The following is a description of a gene set: species: Homo sapiens Human Gene Set: GOBP_CELLULAR_RESPONSE_TO_UNFOLDED_PROTEIN Any process that results in a change in state or activity of a cell (in terms of movement, secretion, enzyme production, gene expression, etc.) as a result of an unfolded protein stimulus., and this is the list of marker genes: QRICH1, DDIT3, SERP1, COPS5, NCK1, EIF2S1, STUB1, CCND1, TM7SF3, ATF6, TMBIM6, DERL1, MIR199A1, CREBRF, MBTPS1, OS9, OPTN (NCBI Gene Id 337928), AKT3, HERPUD1, BCL2L11, AMFR, RHBDD1, DNAJB9, VAPB, UMOD, YOD1, BHLHA15, MBTPS2, HSPB8, DNAJC10, CREBZF, BAX, ATAD3A, MANF, TMTC4, PACRG, PIGBOS1, AKT2, BBC3, RACK1, ATF4 (activating transcription factor 4), TMBIM4, PTPN2, PRKN, TBL2, HSF1, AKT1, SELENOS, DAB2IP, TMEM33, CTH, CDK5RAP3, NCK2, EDEM3, NFE2L2, ERMP1, DAXX, PIK3R1, EDEM2, STC2, PARP6, PARP16, DERL2, HSPA1A, SERP2, ERLEC1, EIF2AK3, DDRGK1, BAK1, CREB3, HSPD1, ASB11, ERO1A, PARP8, RPAP2, ERN2, WFS1, BAG3, CREB3L1, ABCA7, ERN1, PTPN1, VCP, BOK, RHBDD2, XBP1, DERL3, TMED2, RNF7, PPP1R15B, ATF6B, ATF3, FUT1, UFL1, ABCB10, PPP1R15A, HSPA5, BFAR, EIF2AK2, FICD, HERPUD2, AGR2